Given this list of marker genes AKAP8, RMDN3, TSSK2, CARD11, PPP1CA, ATG16L2, PANK4, CHD2, ERCC6L, POLR2D, FXN, ADK, ZNF124, GID8, TCF4, PARK7, RIPOR2, YTHDF2, DANCR, STEAP2, NUDCD1, MLLT6, PKIB, CFAP20DC, PAX5, KRT27, UBTD2, SPATA24, CEP152, TMEM91, CCT5, CCDC150, HSPE1, STOML1, SNX5, CHD6 (chromodomain helicase DNA binding protein 6), ACD, PPP1CC, HADH, SLC2A13, ETV1, TOMM20, FUS, EDARADD, NDST1, LIMD1, CDH10, RPP25L, SHMT2, ACP5, ZBTB11, MEN1, CIITA, PLEKHB1, MAP3K1, BTBD1, JMJD6, CMTR1, PPCS, KIAA1217, HDAC1, CBLL1, STRC, BMP4, DCAF12 (DDB1 and CUL4 associated factor 12), ZSCAN22, CLNS1A, RABGAP1L, NECTIN2, JADE3, UNC5CL, NDUFS4, ZEB1, NTHL1, KCTD3, REV3L, GGPS1, PPP2R5E, RPL35 (NCBI Gene Id 92393), SYT3, PHTF2, USP34, DRP2, B3GNT2, BTRC (beta-transducin repeat containing E3 ubiquitin protein ligase), LONP1, KTI12, IPO4, C16orf54, SRR, IMMP2L, TRNT1, PDE11A, PLA2G12A, RDH11, SEL1L2, ZNF383, GEN1, S100PBP, ELK1, MYO1C, CNPY4, AARSD1, CABLES2, HIC2, ACAT1, TBRG4, RCC2, LSM4, TGIF2, PRRG3, TYMS, SZT2, NUP35, ZNF48, LRRK2, SNX25, MGA, CARHSP1, CTCF, TTC33, FASTKD3, SAC3D1, FPGS, GDAP1L1, ZSCAN20, ME3 (malic enzyme 3), C1GALT1, ITPR3 (inositol 1,4,5-trisphosphate receptor type 3), PHF21A, CYP4F2, FRA10AC1, POM121L2, SETD2, ZNF574, RIMKLB, SCLY, LECT2, GPD2, DDX59, WDR3, IARS1, DCP1A, CIMIP6, DNAJC9, NSUN5 (NOP2/Sun RNA methyltransferase 5), RBMXL1, ZNF24, DGKA, CSGALNACT1, MACO1, LPGAT1 (NCBI Gene Id 9926), CCNT2, PEX12, TMOD3, KCNQ5, PSAPL1, KCNMB4, TIMM50, CEP170B, PDIA4, COL4A5, LRRC42, POLR3E, WDR47, SPG7, PHF6, P3H3, RPL31, SIMC1, CNR1, GRAMD2B, COX10, DNAJC27, POLR1E, EIF1B, GPAT4, ZMYM4, CLPP, SNHG6, MCM7, CEP68, MED31, POLE4, CSNK1G2, GMCL1, C9orf85, CNTROB, IFT140, ENTPD7, FHIP1A, AGTR2, SNX30, USP28, ADNP, STON1, FAM168B, SRSF1, PPIH, WDR64, here is a description of the gene set: Genes up-regulated in comparison of B cells versus NK cells. studied in species Homo sapiens from publication Konuma T, Nakamura S, Miyagi S, Negishi M, Chiba T, Oguro H, Yuan J, Mochizuki-Kashio M, Ichikawa H, Miyoshi H, Vidal M, Iwama A (PMID 21540074) Each fraction of mouse hematopoietic cells was purified by cell sorting from bone marrow of 8-week-old C57BL/6 mice, and its gene expression was analyzed. Human Gene Set: GSE27786_BCELL_VS_NKCELL_UP